The following is a description of a gene set: species: Mus musculus Mouse Gene Set: GOBP_GLYCEROL_3_PHOSPHATE_METABOLIC_PROCESS The chemical reactions and pathways involving glycerol-3-phosphate, a phosphoric monoester of glycerol., and this is the list of marker genes: Gpd1l (glycerol-3-phosphate dehydrogenase 1-like), Gk, Gpat2, Gpd2, Gk5, Gykl1, Gpat3, Gpd1, Slc37a2, Gk2